The following is a description of a gene set: Human Gene Set: GOBP_CELLULAR_RESPONSE_TO_UV_C studied in species Homo sapiens Any process that results in a change in state or activity of a cell (in terms of movement, secretion, enzyme production, gene expression, etc.) as a result of a UV-C radiation stimulus. UV-C radiation (UV-C light) spans the wavelengths 100 to 280 nm., and this is the list of marker genes: EI24, PIERCE1, MDM2, POLH, ST20, TP53